Given this list of marker genes EIF3G, RBM47, SLC25A33, ZNF318, GTF2A2, TARS1, SLC45A1, CITED2, USP32, MMAB, RBM8A, TMEM87A, MAN2A1, CSTF3, RCBTB1, SPRYD4, SRM, HAT1, SYNCRIP, IFT52, HERC4, LONP1, NAMPT, AP4E1 (NCBI Gene Id 23431), FBXO3, LINC-PINT, PCK1, GPATCH4, CDC25B (NCBI Gene Id 994), GCLM, COPS6, FBXW7, NXT2, SDHD, METTL6, RIMBP3, MED6, CDIPT, NIP7, VKORC1, ZDHHC23, NDUFAF4, WDR43, DDX51, DIS3L, PSMD7 (proteasome 26S subunit, non-ATPase 7), RGS10, PPHLN1, UFC1, PNKD, CSPG5, FBXO28, UBE2Q2, ITGA2B, SSBP2, VPS45, UNC119B, PCF11, KAT2A, KICS2, NXPE3, SH3BP5, PRR7, NBAS, LTN1, SNRPE, GCC2, NFATC3, TMEM71, IQGAP2, CAMK4, CAMK1D, HPRT1, TUBGCP6 (tubulin gamma complex component 6), UGGT1, RSU1, ATR, NACA, YTHDC1, UFM1, UIMC1, PSMF1, PSME4, UQCC1, CDV3, RPN2, XPO5, EOMES, NIFK, LATS1, CEP68, SMARCA5, BCL7A, TOB1, RNF141, FTH1, RC3H2, LRPPRC, MYCBP2, LARS1, LCMT2, HNRNPH2, MSH2, MRPS18C, MACROH2A1, PI4KA, IL2, RPP38, PRKD2, NOL9, SESN3, CEP43, SLC39A14, MTCH2, NOP16, POLA1, UROS, BTF3L4, MAP2K1, SUGT1, WDR18, EEF1E1, TAF13, CDK5RAP1, GPR155, ABI2, SMN1, ABHD14A, TASOR2, TAPT1, SNTB1, DCAF8, ZBTB37, NGLY1 (N-glycanase 1), PRKX, GUF1, CELF1, TEX9, NPRL3, ADAMTSL2, SRPK1, ZFAT, PDCD2, FAAH, DCUN1D1, TCP1, CHMP1B, IL1RL2, PWP2 (PWP2 small subunit processome component), PNPLA8, ZEB1, TCF20, PRPF31, TRMT10C, CLCC1, RAP2A, GALNT2, HIVEP2, CCT6A, RAB3GAP1, BPNT1, NME1, PSMA2, ABCB7, SHLD2, URB1, COA3, NUP93, TXN2, VAPA, ZMPSTE24, PDK1, B3GNT8, here is a description of the gene set: species: Homo sapiens Genes up-regulated in TCF7 knockout: DN3 thymocytes versus T cell lymphoma cells. Human Gene Set: GSE33292_DN3_THYMOCYTE_VS_TCELL_LYMPHOMA_FROM_TCF1_KO_UP from publication Yu S, Zhou X, Steinke FC, Liu C, Chen SC, Zagorodna O, Jing X, Yokota Y, Meyerholz DK, Mullighan CG, Knudson CM, Zhao DM, Xue HH (PMID 23103132) TCF-1 is an HMG family transcription factor which is known to be critical for T cell development. We discovered that it has a unique role in suppressing malignant transformation of developing thymocytes at early stages. We identified ID2 and LEF-1 as key TCF-1 target genens in tumor suppression. We used microarrays to detect gene expression changes in WT and TCF-1 deficient DN3 thymocytes as well as T cell lymphoma cells developed in TCF-1 KO mice.